The following is a description of a gene set: species: Homo sapiens Neighborhood of SS18 synovial sarcoma translocation, chromosome 18 in the MORF expression compendium Neighborhood of SS18 Human Gene Set: MORF_SS18, and this is the list of marker genes: OARD1, PRKAG1, FANCG, CNOT2, MRE11, RERE, SEC31A (SEC31 homolog A, COPII coat complex component), METAP1, PIK3CB (NCBI Gene Id 5291), ENTREP1, INPP5E, SH2B1, TAF9, PARN, NELFB, CHD3, NFATC2IP, CDK13, RPRD2, TMEM94, SS18, DDB1, DRAP1, TMEM11, CSTF3, KPNA6, FRYL, CPSF4, CSNK1D, PDXDC1, PLIN3, PRKCSH, BPHL, LEPROTL1, PIK3R2, BAHD1, ZBTB11, DNAJC7, AGPAT1, DIMT1, NFYB, JRK, TPR, PIGB, SLC25A11, MTX1, NUP62, B4GALT3, RBBP8, ATRX (NCBI Gene Id 6475), SMAD2, SSR1, CLPX, TTF2, PIGF, MEA1, IRF2, ENTREP3, TAF2, PCGF1, SFSWAP, MFN2